Given this list of marker genes RNF149, MBLAC2, FAM98A, RBM33, ACTR2, IGIP, E2F3, SLITRK1, FMR1, NCOA3, CAPRIN1, PPP2R5C, SPTY2D1, GZF1, MTSS1, BPTF, BTBD3, ARHGEF2, KPNA4, SEC16B, TRIM14, MOSPD1, SRPK2, SGMS1, BCL6, GPHN, KCNAB1, SCNN1A, here is a description of the gene set: Human Gene Set: GTAGGCA_MIR189 Genes having at least one occurence of the motif GTAGGCA in their 3' untranslated region. The motif represents putative target (that is, seed match) of human mature miRNA hsa-miR-189 (v7.1 miRBase). studied in species Homo sapiens